The following is a description of a gene set: Human Gene Set: GSE26343_WT_VS_NFAT5_KO_MACROPHAGE_UP Genes up-regulated in bone marrow-derived macrophages: wildtype versus NFAT5 knockout. species: Homo sapiens Gene expression from WT and NFAT5 KO primary macrophage cultures. from publication Buxadé M, Lunazzi G, Minguillón J, Iborra S, Berga-Bolaños R, Del Val M, Aramburu J, López-Rodríguez C (PMID 22312110), and this is the list of marker genes: INTS6L, TOR4A, NIPAL3, C16orf54, VPS26C, TOR1B (NCBI Gene Id 84822), POLR2I, H3C14, RAB11FIP5, OPHN1, SFXN1, ANKH, TMEM65, PRP4K, COBLL1, NUDT3, SELPLG, TEP1, MYLIP, FGD6, SLC46A3, TOP2A, SKI, YPEL3, TRMT61A, ENTPD4, DPYSL2, GADD45A, DENND4C, MRPL2, CDH1, RASA3, FAM217B, SEPHS2, ITGAE, MARCHF6, RNF167, ACADM, MARCHF1, EMB, DAB2, NFATC3, ADNP, MRPL12, TMX4 (thioredoxin related transmembrane protein 4), BTBD3, DNMT1, PCYOX1, S1PR1, CRTAP, PAICS (phosphoribosylaminoimidazole carboxylase and phosphoribosylaminoimidazolesuccinocarboxamide synthase), ST8SIA4, PRR14L (proline rich 14 like), EIF4B, SIGMAR1, KIF23 (kinesin family member 23), CD200R1L, MAN2A2, XBP1 (X-box binding protein 1), AP1S3, URI1, MCM6 (minichromosome maintenance complex component 6), LMO2, TMEM165 (NCBI Gene Id 55858), ERP29, TXNDC16 (NCBI Gene Id 57544), MMS19, BPGM, ENOPH1, FOXP1, DDX31, ACOT11, DNAJB14, XRCC6, OSBPL2, FTSJ3, SETX, UTRN, BTK, METTL5, RNASEL, RAB3IL1, GRK6, EDEM3, FAM111A, NAAA, DMWD, NNT, ADSL, HPS3, TRMT2A, CENPA, EXOC8, UCK2, ARL4C, C5orf34, NCAPG2, C9orf85, MTIF2, CASP9, RBBP9, AMZ1, PAN3, RFWD3, GTF2I, PATZ1, GALNT9, INTS11, PRPS2, SLC35C1, MYCBP2 (NCBI Gene Id 55685), MIS18A, SLCO3A1, TNKS2, CBX3, NCOA1, CDK20, ARFGEF2, LDLRAD3, WDR13, MRC1, AURKA, SLC45A4 (NCBI Gene Id 57210), TNKS, TNRC6B, ITCH, NAA60, ZNF710, RMND5B, FADS1, KDELR1, ZFP90 (NCBI Gene Id 146198), SH2D3C, MSH6, C19orf48P, POGLUT2, NR1D2, ENC1, PELI2, GSK3B, CDK2 (NCBI Gene Id 1017), SLBP, KLHDC10, MATK, MANBA, ENTPD1, L1CAM, SPAST, POLK, ATRX, MAF (NCBI Gene Id 4094), ZMAT3, DOLK, GNE, C2orf69, ANKRD40, REEP4, RNF169, SPTBN1, CDKN2C, RNF44, NET1 (NCBI Gene Id 10276), PPOX, RPS6KA4, MRGPRE, ST3GAL4, ZNF395, ABHD17A, MYC, INPP4A, ADI1, SEPTIN9, BORCS6, ZBTB45, COMT, ABL1, AP2A2, GLRX5, SLC35E3, MTMR3, LPXN, GALK2, PNN, CTBP1, NRBF2, HLTF, RAP2A, CHST14, GSN, SLC26A11, HPGD, APPL2, PLPP2, SSH2, NFATC2, ZFP91, SLK, SNX1, ASB8, SH2D5